The following is a description of a gene set: The process whose specific outcome is the progression of the metanephros over time, from its formation to the mature structure. In mammals, the metanephros is the excretory organ of the fetus, which develops into the mature kidney and is formed from the rear portion of the nephrogenic cord. The metanephros is an endocrine and metabolic organ that filters the blood and excretes the end products of body metabolism in the form of urine. species: Homo sapiens Human Gene Set: GOBP_METANEPHROS_DEVELOPMENT, and this is the list of marker genes: HOXC11, ID2, SOX9, AQP2, IRX2, HES5, WWTR1, HOXA11, SALL1, SIX2, HNF1B, FGF8, SOX17, ADIPOQ, PDGFA, SPRY1, AKR1B1, OSR2, NPHS2, SLC22A1, KIF26B, LGR4, GREM1, WNT7B, AGTR2, WNT4, EGR1, GDNF, OSR1, ITGA8, LAMB2, CD34, SMAD4, DLG5, SIX1, GPC3, IRX3, RDH10 (NCBI Gene Id 157506), RET, PDGFRA, CITED1, LIF, STAT1, LHX1, PKD1, PAX8 (NCBI Gene Id 7849), APH1A, SIX4, BMP7, FOXD1, GDF6, IRX1, TCF21, UMOD, SLC22A6, PDGFB, WT1, FGF10, POU3F3, FOXC2, NF1, MYC, SHH, SOX8, GREB1L, FRAS1, WNT9B, PKD2, PDGFRB, ID3, NIPBL, SMO, CTNNB1, ACAT1, BASP1, PTCH1, ROBO2, GDF11, TFAP2B, FBN1, NKX3-1, PAX2, EYA1, CTSH (cathepsin H), FOXJ1, CALB1, HES1, BMP4, AQP1, GLI3, BCL2, YAP1